Given this list of marker genes WFS1, UCP3, MTNR1B, IL6, TCF7L2, NR0B2, NEUROD1, PDX1, HNF1B, HNF4A, AGRP, IRS2, HNF1A, SDC3, POMC, IRS1, SLC30A8, HMGA1, PAX4, PPP1R3A, GHRL, GPD2, MAPK8IP1, IGF2BP2, CARTPT, ADRB3, RETN, LIPC, PTPN1, SLC2A2, ENPP1, GCK, ABCC8, AKT2, PPARG, here is a description of the gene set: species: Homo sapiens A deviation from normal of the waist to hip ratio, defined as the waist measurement divided by hip measurement. Abnormal waist to hip ratio Human Gene Set: HP_ABNORMAL_WAIST_TO_HIP_RATIO